Given this list of marker genes GJA1, TPPP3, CHN2, SYNGR3, CXCL14, TENM3, here is a description of the gene set: studied in species Homo sapiens Genes up-regulated in pleura relapse of breast cancer. We explored whether the five previously reported molecular subtypes in breast cancer show a preference for organ-specific relapse and searched for molecular pathways involved. The intrinsic gene list describing the subtypes was used to classify 344 primary breast tumors of lymph node-negative patients. Fisher exact tests were used to determine the association between a tumor subtype and a particular site of distant relapse in these patients who only received local treatment. Modulated genes and pathways were identified in the various groups using Significance Analysis of Microarrays and Global Testing. Bone relapse patients were most abundant in the luminal subtypes but were found less than expected in the basal subtype. The reverse was true for lung and brain relapse patients with the remark that absence of lung relapse was luminal A specific. Finally, a pleura relapse, although rare, was found almost exclusively in both luminal subtypes. Many differentially expressed genes were identified, of which several were in common in a subtype and the site to which the subtype preferentially relapsed. WNT signaling was up-regulated in the basal subtype and in brain-specific relapse, and down-modulated in the luminal B subtype and in bone-specific relapse. Focal adhesion was found up-regulated in the luminal A subtype but down-regulated in lung relapse. The five major molecular subtypes in breast cancer are evidently different with regard to their ability to metastasize to distant organ(s), and share biological features and pathways with their preferred distant metastatic site. Human Gene Set: SMID_BREAST_CANCER_RELAPSE_IN_PLEURA_UP from publication Smid M, Wang Y, Zhang Y, Sieuwerts AM, Yu J, Klijn JG, Foekens JA, Martens JW (PMID 18451135)